The following is a description of a gene set: Tumor growth is associated with a profound alteration of myelopoiesis, leading to recruitment of immunosuppressive cells known as myeloid-derived suppressor cells (MDSCs). Analyzing the cytokines affecting myelo-monocytic differentiation produced by various experimental tumors, we found that GM-CSF, G-CSF, and IL-6 allowed a rapid generation of MDSCs from precursors present in mouse and human bone marrow (BM). BM-MDSCs induced by GM-CSF+IL-6 possessed the highest tolerogenic activity, as revealed by the ability to impair the priming of IFN- -producing CD8+ T cells upon in vivo adoptive transfer. Moreover, adoptive transfer of syngeneic, GM-CSF+IL-6-conditioned MDSCs to diabetic mice transplanted with allogeneic pancreatic islets resulted in long term acceptance of the allograft and correction of the diabetic status. Cytokines inducing MDSCs acted on a common molecular pathway. Immunoregulatory activity of both tumor-induced and BM-derived MDSCs was entirely dependent on C/EBP transcription factor, a key component of the emergency myelopoiesis triggered by stress and inflammation. Adoptive transfer of tumor antigen-specific CD8+ T lymphocytes resulted in therapy of established tumors only in mice lacking C/EBP in myeloid compartment. These data unveil another link between inflammation and cancer and identify a novel molecular target to control tumor-induced immune suppression. We used gene expression analysis to identify those factors, secreted by tumor-infiltrating MDSC, which could drive emathopoiesis. Moreover we compare gene expression profile of tumor-induced MDSC, obtained from either the spleen and the tumor infiltrate of tumor bearing mice, and in vitro bone marrow-derived MDSC. from publication Marigo I, Bosio E, Solito S, Mesa C, Fernandez A, Dolcetti L, Ugel S, Sonda N, Bicciato S, Falisi E, Calabrese F, Basso G, Zanovello P, Cozzi E, Mandruzzato S, Bronte V (PMID 20605485) Genes up-regulated in spleen CD11b cells: BALBc versus C57BL6 mouse strains. Human Gene Set: GSE21927_BALBC_VS_C57BL6_MONOCYTE_SPLEEN_UP studied in species Homo sapiens, and this is the list of marker genes: PUM1, FAM185A, GALNT3, ETAA1, DACT1, PSKH2, AFF1, SLC40A1, AGO2 (argonaute RISC catalytic component 2), DCAF16, DDX17, FUT9, SUSD1, ZFYVE16, DNA2, FNBP1L, MXI1, NSUN7, COL5A1, NOX5, DDX47, PNPLA7, DTX4, ADPRM, E2F3, IFNA8, MTBP, ALG2, BACH2, CSPG4BP, ZNF618, KLHL2, PART1, PLEKHG4B, LNX2 (NCBI Gene Id 222484), ZFYVE1, BEX4, ESRG, TBL1X, ARHGAP39, STMP1 (short transmembrane mitochondrial protein 1), CACUL1, ST7L, NRARP, TPSD1, LHFPL2 (NCBI Gene Id 285713), TMEM192, LAMP2, KRT19, RMDN1, LCDR, ANAPC7, ADGRG3, PPIL6, HLF, FAT3, LEF1, MAP3K2, TSPAN15, NPHP3 (NCBI Gene Id 27031), SNX22, SPDL1, ZNF134, PPP1R7, CCDC14, ATF6B, H3C10, STAM, CHRND, AMN1, PUDP, CYP2R1, UTRN, TWF1 (twinfilin actin binding protein 1), CFAP90, H2AC8, CCNG2, MED30, DEUP1, MRE11, RBMS1, CHUK, SETDB2, BDH2, AIDA, CENPBD1P, XG, LINC01553, ABCB4, PDIA5, PABIR2, CLDN12, GPR19, ABTB3, APOBEC3C, SSBP2, LRRC15, IRS2, ZBBX, CPNE8, FMO5, CLCN6, GPR31, SBF2, ZNF829, ZNF738, GPALPP1, H2AC6, KLHL28, SELENOF, AKAIN1, PARD6B, HOOK3, MMUT, RPS6KA3, PDCD4-AS1, APIP, ZNF512, KAT2B (lysine acetyltransferase 2B), WTIP, PELI2, TRPS1, SORL1, ZNF470, H2BC7, NME8, TMEM263, DLEU7, H2BC8, TPST1, AGPAT4, ZNF285, UGT2A3, EBLN3P, H2BC12L, FBXO30, CMTM3, PI4K2B, ADARB1, OGFRL1, FMN1, TCP10L3, ZNF354B, ARRDC4, NFYA, TNFRSF21, TCL1A, C8orf34, P2RY14, GCA, ZNF438, HIP1, ZNF529, DBP, ATXN2L, SOX8, ZNF562, TMPO, DLEU2, FARSB, CYP4B1, ZWILCH, PBLD, PSRC1, SLC6A16, ALG10B, RUBCNL, CAMK2N2, ZCCHC7, SNX30 (sorting nexin family member 30), AAK1, NGRN, GABPA, KLHDC8A, TRABD2A, CDK6, REPS1, MCMDC2, VNN2, ZNF709, SIAH1, PLEKHA2, OR7E156P, GPR20, MTERF3, ZNF629, CCN2, CD47, UXS1